The following is a description of a gene set: part of: Platelet activation, signaling and aggregation This event has been computationally inferred from an event that has been demonstrated in another species.<p>The inference is based on the homology mapping from PANTHER. Briefly, reactions for which all involved PhysicalEntities (in input, output and catalyst) have a mapped orthologue/paralogue (for complexes at least 75% of components must have a mapping) are inferred to the other species. Reactome Pathway: Platelet Aggregation (Plug Formation) electronically inferred by orthology from the curated human pathway studied in species Mus musculus, and this is the list of marker genes: Csk, Gp9, Ptk2, Pdpk1, Fgg, Tln1, Gp1bb, Col1a2, Syk, Adra2a, Ptpn1, Apbb1ip, Shc1, F2, Grb2, Rasgrp1, Bcar1, Gp1ba, Adra2c, Itga2b, Adra2b, Crk